Given this list of marker genes Bcl2l2, Bax (BCL2-associated X protein), Fshb, Esr2, Fshr, Fgf9, Esr1, Acvr2a, here is a description of the gene set: Mouse Gene Set: GOBP_SERTOLI_CELL_PROLIFERATION The multiplication or reproduction of Sertoli cells, resulting in the expansion of the Sertoli cell population. A Sertoli cell is a supporting cell projecting inward from the basement membrane of seminiferous tubules. studied in species Mus musculus